The following is a description of a gene set: Human Gene Set: GSE34179_THPOK_KO_VS_WT_VA14I_NKTCELL_UP studied in species Homo sapiens Genes up-regulated in Va14 invariant NKT cells: ZBTB7B knockout versus wildtype. We sought to identify genes regulated by the transcription factor Th-POK (Zbtb7b) in liver Va14i NKT cells, by RNA microarray analysis of global gene expression in Va14i NKT cells from mice homozygous for the Th-POK-inactivating hd point mutation as compared with the same cell population isolated from heterozygous or wild-type age-matched mice. from publication Engel I, Zhao M, Kappes D, Taniuchi I, Kronenberg M (PMID 23034280), and this is the list of marker genes: REC114, TFEB, TNN, MCM3AP, CALML5, RHEBL1 (NCBI Gene Id 121268), PRR22, NPL, IRGQ, RGL2, VSX2, PPP1R12B, EREG, ALKBH8, PALS1, SF3B1, ANKRD13D, CCDC167, B3GALT5, FRS3, ERCC6, RTEL1, TMEM53, CAMTA1, SRCAP, POU2AF2, CRB3, POU5F1, RASGRP2, NAT9, TP53I13, SESN1, PLD6, MPV17L, TGFB1I1, OPRL1, ADAMTS4, LACTB2, DPP9, RABEPK, PDCD6IP, PPP1R21, TMEM116, MCTP1, COX20, HEY1, ZMYND11, BRME1, C3orf52, MID2, CLDN15, ADGRE5, ORAI3, PSEN2, AFMID (arylformamidase), GPNMB, ZG16, DAPL1, NXPH2, ANGEL2, FAM13B, FLVCR2, EIF4G1, NOSTRIN, CAMLG, VAMP5, TMPRSS15, NSD1, LTK, RBM25 (RNA binding motif protein 25), SFMBT2, PMM1, TFPT, GORAB, SCAP, CAMK1, LRRCC1, AP1M2, ASZ1, HYAL3, TMEM106B, ARFGEF1, APCDD1, LGR4, FAR2, ITGB1, USP28, IGSF9B, RHPN2, MGA, SERPINI1, ARSJ, TSPYL5, IRS2, SNAI2, DMRT2, ARID3B, NR2F1 (nuclear receptor subfamily 2 group F member 1), C2CD2L, ENPP5, ARHGAP45, RAB3IP, ABI3BP, CRLF3, LHX8, ZNF493, MAP4K5, CD34, CKMT1B, MACROD2, HOXC4, CTNNA2, PAF1, DNM2, ZNF451, GUCY2C, ZNF579, NCK2, TIMP2, PHLDB2, TFAP2A (NCBI Gene Id 95131), SLC25A33, PFKFB2, COX7B2, LAMB3, GGT1, ZNHIT3, MEIOC, NETO2, SPEF1, BAZ2B, FGF6, KIAA0930, ARMC12, PACS1, BCLAF1, TCN2, BLOC1S5, HSD17B1, USP11, HMGA2, SNX14, TMEM71, KIAA1143, BCLAF3, MPP2 (NCBI Gene Id 4355), GFRA4, CLDN12, UCN2, KCNA1, NLRX1, TACC2, TNS1, MYO5C, SEPTIN14, NUCB2, GCLM, ELANE, FGD5, IL18BP (interleukin 18 binding protein), B3GALT2 (beta-1,3-galactosyltransferase 2), CFAP251, SLC13A4, PTPN5, PLPPR2, ZNF865, ATP11A, FANCD2, FAM124B, GCDH, TMEM141, RAPH1, HSDL1, ST6GALNAC3, ACSBG1, RNPEPL1, OGFOD3, ARHGAP31, CYP3A7, CHI3L1, PTGDR, KIN, IKBKB, ME1, IFI44, TKTL1, G6PC2, WNT5B, SBSPON, TP53BP2, PBLD, PDZRN3, SOX30, TRMT1L, SCN11A, GRINA, CHRNB2, TMEM125, TMEM67, RTF2